The following is a description of a gene set: Mouse Gene Set: GOMF_PEROXISOME_PROLIFERATOR_ACTIVATED_RECEPTOR_BINDING Binding to a peroxisome proliferator activated receptor, alpha, beta or gamma. species: Mus musculus, and this is the list of marker genes: Tacc1, Ikbkg, Hmga1, Prmt2, Ep300, Dut, Lpin1, Ncor1, Hmga1b, Ncoa6, Nfatc4, Mdm2, Asxl3, Asxl2, Med1, Ncoa3, Rpl11, Ppargc1a, Esr2, Nr0b2, Asxl1, Crebbp